The following is a description of a gene set: species: Mus musculus Any process that modulates the frequency, rate or extent of multicellular organismal development. Mouse Gene Set: GOBP_REGULATION_OF_MULTICELLULAR_ORGANISMAL_DEVELOPMENT, and this is the list of marker genes: Osr2, Thbs2, Cdh1, Alox8 (arachidonate 8-lipoxygenase), Racgap1, Uchl5, H2-DMa (NCBI Gene Id 14998), Cul4a, Tnfrsf11b, S1pr1, Lrrtm3, Rbm19, Ccr7, Cxcl12, Mycl, Fxr1 (NCBI Gene Id 99741), Fbxo31, Bmp2, Ptger4, Helt, Pak1, Col4a2, Fam20c, Krt17 (keratin 17), Trpm4, Fos, Spart, Adgrb2, Lrp8, Sorl1 (NCBI Gene Id 72910), Prl8a8, Pla2g3, Ryk, Trp53, Mir124a-2, Six2, Rag2, Zmpste24, Tox, Efnb3, Mysm1, Asic2, Jag1, Dyrk1a, Cdk1, Foxn1, Tlr9, Gab1, Sox4, Id4, Khdc3 (NCBI Gene Id 66991), Plcg1, Dlg1, Lama3, Egr2, Pax2, Lingo4, Sema4d, Fadd, Tnfrsf12a (tumor necrosis factor receptor superfamily, member 12a), Zbtb46, Inpp4b, Pik3r6, Il18, Hoxa11, Smarcc1, Pglyrp4 (peptidoglycan recognition protein 4), Apela, Tmem100, Zfpm1, Vax1, Nlgn2, Il17a, Klf4, Spint1, Tnfrsf1b, D130043K22Rik, Nfkbid, Ppargc1b, Ptk2, Trpc5, Slitrk1, Slc25a4, Bmyc, Wt1, Aplnr, Zeb2, Thrb, Sh3glb1, Kcnk18, Tradd, Mfn2, Clstn1, Rhoh, Ino80d, Lhx2, Smad3, Fgfr1, Ccl21b, Plcb1, Bcor, Mafg, Prl2b1, Akt1, Islr2, Lrrn1 (NCBI Gene Id 72710), Zpr1, Slitrk5, Sgms2, Gpr55, Zzz3, Ythdf2, Rassf10, Itgb2, Lrg1, Smarce1, Ptch1, Rps6ka6, Dcstamp, Cdh4, Hdac2, Hltf, Star, Ski, Dlg5, Csf3r, Mir1a-2, Foxg1, Actr3, Mir675, Erbb2, Prl8a1, Eppk1, Mitf, Foxc1 (NCBI Gene Id 17300), Lep, Tyrobp, Smap1, Rela, Fst, Anxa3, Ano6, Cysltr1, Vgll4, Cst7, Xrcc2, Mbp, Nme1, Numb, Wnt6, Phlda2, Srf, Hax1, Dkk4, Dixdc1, Tcim, Pira12, Tbx3, Prl6a1, Ap3b1, Il5, Hrg, Macroh2a1, F2, Ttc3 (NCBI Gene Id 70444), Metrn, Clasp2, Hhex, Cebpa, Kras, Parp2, Caprin1, Clstn2, Dpysl5, Met, Srrt, Hopx, Tjp1, Actr5, Zfp488, Ccm2, Apcs, Hpse, Sfrp4, Vegfc, Ostn, Fbxw7, Jmjd8, Tal1, Ank, Ppp1r16b, Rassf2, Scin, Trem2, Nap1l1 (nucleosome assembly protein 1-like 1), Mtor, Ephb3, Dnajb11, Atraid, Ctsh, Ctnnbip1, Ptpn2, Tescl, Slit2, Clec4g, S100b, Cd27, Il34, Foxa2, Tdg, Tle6, Twist2, Stat5a (NCBI Gene Id 20850), Fas, Cdkl3, Rgs2, Ceacam1, Braf, Septin7, C3ar1, Kat14, Adcyap1, Tcta, Vhl, Wnt2 (NCBI Gene Id 93808), Bhlhe40, Cx3cl1, Ccl5, Fn1, Prkca, Sos1, Lnpk, Pias3, Chadl, C1qc, Bglap3, Dcx, Il15ra, Plxnb2, Gfi1b, Epha7, Foxj2, Rnd2, Bmp10, Gas6, Pou4f1, Jam2, Cd74, Sp100, Adam8, Klf10, Ocstamp, Grn, Grm5, Maff, Prl8a6, Cxcr3, Fbxo7, Frzb, Gsx2, Shtn1, Trib1, Spry1, Mbd1, Pi16, Tmem176b, Nme2, Trps1, Jun, Cdc73, Tada3, Kitl, Zdhhc21, Shb, Zfp335, Il4i1, Tomm70a, Tmem64, Cartpt, Fgfr3, Hgf, Ptn, C3, Duxbl1, Apoe, Il17f, Pkdcc, Hmga2, Akap5 (NCBI Gene Id 70774), Ctr9, Fbxo5, Csf1, Pin1, Ufl1, Sult2b1, Appl2, Prl7d1, Gadd45a, Mef2c (myocyte enhancer factor 2C), Crabp2 (NCBI Gene Id 99759), Sirt6, Chodl, Il36b, Clec2g, Mustn1, Hook3 (NCBI Gene Id 76095), Esrra, Adam12, Hes6, Pcm1, Plk2 (NCBI Gene Id 20620), Mir125a, Nkap, Dspp, Ezh2 (NCBI Gene Id 14056), Ecscr, Dct, Ntf3, Draxin, Leo1, Itga5 (NCBI Gene Id 16402), Mydgf, Prune1, Iqsec1, Rxrb, Ccn4, Il12b, Ggcx, Igf2, Gm28729, Runx2, Vdr, Tnfsf18, Prl8a2, Gfap, Il17d, Cd109, Erap1, S1pr3, Flrt2, Fam210b, Foxo3, Inhba, Angpt2, Bdnf, Prl4a1, Fshr, Ecm1, Egr3, Lig4, F11r, Sars1, Bcl6, Mkx, Ctdp1, Gbx2, Spen, Cd1d1 (NCBI Gene Id 99710), Lrrc17, Foxa3, Ache, Rxrg, Prok1, Prl5a1, Actr2, Sema4f, Dll4, Poglut1, Vsx2, Hipk2, Sema3e, Mtdh, Ihh, Optc, Ngp, Mapk8, Matn1, Prkch, Il3, Fasl, Bmp7, Lrrtm2, Ddr2, Itgax, Bmpr2, Cers2, Hoxd11, Prkd2, Nrxn1, Nsun5, Prkg2, Fbn1, Fzd4, Syk, Il2, Mboat2, Cyp27b1, Il7r, Smarcd2, Tpbg, Ovol2, Prdm16, Wdpcp, Hspa1b (heat shock protein 1B), Col14a1, Nodal, Rhoa, Rbp1, Cbln2, Smarca4, Otp, Tbx2, Actn3, Il7, Mmp9, Daam2, Zc3h8, Hspb1 (NCBI Gene Id 15507), Tjp2, Fgf1, Sox11, Trip10, Hamp2, Pira1, Fdps, Actl6a, Slitrk2, Lgals9, Rbm10, Mir329, Ppp3ca, G6pdx, Ankrd27, Reln, Fmr1, Yy1, Agrn, Rbm15, Cnmd, Tfpt, Lrrn3, Pilrb1, Rpl4, Marcks, Ell3, Pxn, Mtmr2, Ephb1, Aspm, Epha1, Atf5, Drd3, Nrg1 (neuregulin 1), Prom1, Mir301, S2bpcox16, Pard3, Cyp26b1 (cytochrome P450, family 26, subfamily b, polypeptide 1), Cdkn2a, Map1b, Atp2b1, Cd160, Iapp, Wnt1, Rhob, Hey1, Prmt1, Adgrv1, Rnf10, Angptl3, Clcf1, Anxa1, Notum, Pdcd6, Ptk2b, Trak1, Chd7, Hoxa9, Prl7a2, Gimap3, Tbxa2r, Cav3, Cma1 (NCBI Gene Id 17228), Il1rapl1, Esrp1, Rgs4, Cited2, Wdr62, Xrcc6, Emilin2, Cdkn2b, Sgf29, Smo, Nfkbia, Crtam, Extl3, Jcad, Tbx1, Tespa1, Cit, Adgra2 (NCBI Gene Id 78560), Arhgap4, Fgfr2, Atf4, Gdf2, Igf1, Gjc2, Mup20, Mir23a, Ruvbl1, Tlr3, Drosha (NCBI Gene Id 68645), Ctsc, Hey2, Gpr171, Nell1, Mir27b (microRNA 27b), Pdcd10, Angpt4, Msx1, Abcb10, Heyl, Grhl1, Cdk5, Atp11c, F3, Wnt9b, Acvr2a, Camk2b, Sgpp1, Adgrl4, Rnh1, Sirt2, Mapk7, Lag3, Trak2, Hspb6, Hc, Ldlr, Clec12a, Plxnb1, Tek, Mir219a-2 (NCBI Gene Id 723904), Foxp4 (forkhead box P4), Maf, Ap3d1, Gli1, Adamts7, Rheb, Prkd1, Tnfrsf1a, Gli2, Pax6, Ctdsp1, Ndel1, Ccl2 (NCBI Gene Id 20296), Irf1, Stard13, Ahi1, Tppp, Robo1, Bin1, Pgf, Ascl1, Il23a, Gdf3, Cyp1b1, Six4, Hoxb8, Nkx2-2, Otx2, Prl3d1, Clasp1 (NCBI Gene Id 76707), Nipbl, Ccr1, Fgf9, Idh2, Mir124a-3, Xdh, Ccbe1, Pik3r1, Eif4g2, Vash2, Pkp3, Zfp354c, Gata4, Epn2, Ep300, Map2k1, Nrarp, Dab2ip, Dsg2, Vash1, Lama5, Pnp, Errfi1, Il1a, Atoh1, Pax8, Ago1, Cldn5, Vim, Psen1, Enpp2, Evi2, Zap70, Myoz1, Lta, Six1, Axin2, Tbx5, Myrf, Il1b, Mme, Itgb8, Clec2i, Rc3h1, Mir208a, Cd46, Mt3, Wnk1, Tgif2, Prl2c2, Prl2c3 (prolactin family 2, subfamily c, member 3), Prl7c1, Kat6b, B2m, St8sia2, Tspo, Hmgb1, Slc20a2, Etv2, Limk1, Hhip, Ccl20, Ing5, Hesx1, Nfatc4, Mepe, Pten, Brd7, Brpf3, Pithd1 (NCBI Gene Id 99969), Gli3, Lpin1, Gimap5, Ntrk3, Chi3l1, Vsir, Lama1, Ptprs, Amot, Itgb1, Sox5, Ror2 (NCBI Gene Id 26564), Cd44, Btg1, Dtx1, Twf2, Glg1, E2f2, Lif, Zbed3, Pik3cd, Pias2, Gsdma3, Sart1, Prkcb, Nr2c2, Adgrl3, Ctla4, Prxl2a, Glul, Atg7, Tmem178, Ajap1, Pgk1, Cdh2, Csf3, Wdr5, Cd36, Rras, Insr, Tbc1d24, Dr1, Serpinf1, Acacb, Ctnnb1, Myc, Socs5, Mturn, Slc9b2, Hes2, Fbln5, Hes5, Epha2, Il1rl2, Oprm1, G6pd2 (NCBI Gene Id 14382), Mbip, Apc, Por, Thy1, Ntn1, Hgs, Nlrp3, Map6, Psg22, Nfam1, Tymp, Eif2b2, Hoxb3, Fezf2, Ccr6, Loxl2, Xrcc5, Axl, Fes, Sphk1, Il2rg, Pik3cb, Adgrb1, Lox, Rtn4, Gdf6, Sash3, Nr1d1, Casp8, Slamf8, Cux2, Faim, Spred1, Tgfbr2, Ncmap (NCBI Gene Id 352981), Rnf112, Isl1, Hdac1, Retn, Il21, Yeats2, Trp73, Ccl11, Skic8, Macf1, Ddrgk1, Tbx20 (NCBI Gene Id 77243), Stab1, Nfe2l1, Srebf2, Prelid1, Sox2, Cdk18, Erbb4, Pin1rt1, Lrtm2, Tnfrsf21, Oas2 (2'-5' oligoadenylate synthetase 2), Thbs4, Hes3, Clstn3, Tsc22d1, Mcrs1, Il4, Vegfa, Tnfsf9, Epn1, Parp6, Krt36, Rhoj, C5ar1, Rgcc, Zbtb7b, Ninj1, Adrm1, Stim1, Mapt, Rock2, Eif6, Smarcd3, Lef1, Gja1, Mesp1 (NCBI Gene Id 17292), Kcnk2, Cul7, Tgfb2, Or10j5, Bmpr1a, Bglap2, Grem1, Ppp1cc, Sash1, Acin1, P2rx7, Sox10, Gorasp1, Ndfip1, Kat7, Comp, Myh6, Smarcd1, Sema3a, Nr5a1, Meaf6, Utp25, Srpx2, Bmp2k, Apold1, Hdac6, Nfe2, Sema7a, Efna5, Il4ra, H2-Oa, Prl2a1 (NCBI Gene Id 56635), Ifng, Atf2, Nfe2l2, Dcn, Etv4, Rab14, Rb1 (NCBI Gene Id 19645), Egf, Tspan18, Rarb, L3mbtl1, Ddah1, Cd276, Pafah1b1, Myod1, Plxnd1, Plxnc1, Slc30a1, Xbp1, Tnfrsf11a, H2-Ea, Ptpra, Sh3rf1, Ikzf3, Ncam1, Zmiz1, Mir24-2, Prl3c1, Ephb2, Tnfsf11, E2f1, Adamts1, Snap91, Lck, Asxl2, Rarg, Acvr2b, Neurl1a, Flrt3, Cux1, Prl3b1, Efna3, Il10, Siglec15, Wasf3, Mmp14, Crb2, Ino80b, Plxna3, Ascl2, Lilrb4a, Rest, Keap1, Mir133a-1 (microRNA 133a-1), Plxnb3, Mfn1, Gtf2i, Tnfaip6, Pglyrp3, Amigo2, Pbrm1, Kat2a, Sfrp2, Cxcr2, Tgif1, Jup, Sema5a, Evi2b, H2-M3, Actb, Malt1, Sav1, Lgals1, Pkm, Mettl3, Trpv2, Fgf23, Ptch2, Nkx2-5, Wnt4, Rab7b, Prl8a9, Rnf41, Gdf5, Shank3, Btn2a2, Il12a, Commd5, Picalm, Capn3, Rgma, Fgl2, Gsk3a, Fezf1, Mir223, Dynlt1b, Oxt, Zbtb1, Ankrd54, Vnn1, Bcl11a, Sgms1os1, Ccr5, Zfp418, Gbx1, Pak4, Runx1, Cysltr2, Ccn2, Plg, Amigo3, Tnf, Lgals3, P4htm, Paf1, Adam10, Kat6a, Crhr2 (NCBI Gene Id 12922), Oxtr, Trim46, Qki, Isg15, Adipoq (adiponectin, C1Q and collagen domain containing), Fbn2, Tspan12, Pth, Slitrk3, Wnt5a, Rgn, S100a10 (NCBI Gene Id 99776), Mpl, Dlk1, Grid2 (glutamate receptor, ionotropic, delta 2), Adrb2, Mafb, Man2a1, Prkci, Pik3cg (NCBI Gene Id 76039), Lrp1, Kalrn, Id2, Cx3cr1, Adamts12, Hnrnpk, Cbfb, Rorc, Tnr, Hif1a, Lilrb4b, Wnt7b, Emilin1, Cd40, Agt, Ripk2, Wnt3, Wnt9a, Egln1, Loxl3 (lysyl oxidase-like 3), Foxp3, Acvr1b, Twist1, Suv39h1, Inpp5d, Scx, Tfap2a, Phldb1, Ada, Abl1, Zfp35, Fzd3, Hes7, Zfp365, Ccr3, Adgrl2, Cask, Sox13, Syngap1, Pdpk1, Ferd3l, Sema6d, Ikzf1, Ets1, Fanca, Zfp36, Btg2, Reck (NCBI Gene Id 53614), Rasgrp1, Ccnd2, Bad, Shc1, Gnas, Ipo7, Tada2a (transcriptional adaptor 2A), Cyfip1, Creb1, S1pr2, Dll1, Prl3a1, Cd34, Cdk6, Skint1, Ghrl, Txlng, Epha4, Ctf2, Mia3, Ccl3, Tgm2, Mdga1, Ctla2a, Atp2b4, Flt3l, Faxdc2, Ldb1, Aspa (NCBI Gene Id 11484), Gata6, Actr8, Abcc8, Rgs14, Prdx2, Nfkbiz, Adrb1, Il2ra, Gpr137, Ace (NCBI Gene Id 11421), Rcor1, Cdkn1b, Trf, L1cam, Mecp2, Zfp219, Wnt3a, Reg3a, Pck1, Cdh5, Hnf4a, Fxr2, Clptm1, Eef2k, Stat5b, Il27, Cnot4, Numbl, Cebpb, Gpr68 (G protein-coupled receptor 68, NCBI Gene Id 238377), Ccnd1, Stat3, Nos1, Adamts9, Vegfb, Gh, Srgn, Fbxw8, Tmem119, Hmgb2, Shh, Itgb2l, Ino80 (INO80 complex subunit), Rbfox2, Bag6, Smarcb1, Fgf10, Sema3g, Cd24a, Ptgis, Snw1, Krit1, Atxn1, Egfr, Tgfbr3, Fxn, Sox6, Fzd9, Ube2v2, Odaph, Adm, Gper1, Spi1, Skil, Tiam1, Irgm1, Tafa5, Kdf1, Bmal1, Hspa9, Mapk11, Tob2, Arid1a, Bmp6, Rara, Lrrtm4, Itpka, Cdon, Dag1, Foxc2, Lingo1, Syt4, Bmpr1b, Trp63, Kit, Zeb1, Trim32, Hmox1, Trpc6, Efna1, Bex1, Ruvbl2, Lmo2, Casz1, Rnf6, Cd69, Ripk1, Thoc5, Dab1, Mycn, Klhl25, Hes1, Trip12, Il6st, Zfp683, Bhlhb9, Dlg4, Sirt1, Col4a3, Mir219a-1, Amigo1, Ahsg, Foxp1, Eng, Prpf19, Smad1, Car2, Musk, Camp, Tiam2, Slc4a2, Thpo, Tlx2, Cib1, Synj2bp, Nlgn1, Rbp4, Kdr, Ghsr, Cdkn1c, Gal, Cxcl10, Lrp2, Ifrd1, Elapor2, Kat2b, Prox1, Tgfb1, Ntrk1, Wwtr1, Dmrta2, Smoc2, Fgf20, Jade2, Dusp6, Ccr2, Tfe3, Mag, Adgrl1, Sema3f, Cdh3, Ywhah, Anapc2, Cyld, Arhgef2, Mdk, Itgb3, Prl2c5, Ankle1 (ankyrin repeat and LEM domain containing 1), Ctsk, Carmil2, Mir326, Myo5b, Ppard, Hyal1, Tmem131l, Foxe3, Ltf, Rapgef3, Pdcl3, Mmrn2 (NCBI Gene Id 239033), Lhx1, Tnmd, Tg, Ctnna1, Fig4, Hlx, Angptl7, Rufy3, Ddx39b, S100a1, Gpr37l1, Ifnb1, Serpine2, Mir7-1, Gpm6b, Edn1, Sox9 (NCBI Gene Id 70015), Hoxa5, Prkcz, Ambra1 (NCBI Gene Id 99255), Fstl4, Idua, Arrb2, Shox2, Hap1, Mgp, Pparg, Sh2b3, Fstl3 (follistatin-like 3), Enpp1, Cxcr4, Notch1, Per2, Prl, Lrrc4b, Nf2, Kdm1a, Zc3h12a, Fyn, Clec2d, Ino80c, Hk2, Ngf, Clcn2 (chloride channel, voltage-sensitive 2), Klf7, Akap6, Wnt2b, Bmp1 (NCBI Gene Id 12153), Kl, Mapk14, Rflna, Itgam, Syndig1, Spred3, Ptpn11, Fancd2, Afdn, Yap1, Uts2r (urotensin 2 receptor), Dhx36, Rock1, Dbnl, Slc25a12, Tapt1, Cav1, Sparc, Reg3g, Efemp1, Cbln1, Ncoa3 (NCBI Gene Id 99361), Acvr1, Bglap, Fgf2, Arhgap32, Meis2, Gata1, Ccsap, Dlx1, Nras, Sfn, Gata3, Cd28, Agtr1a, Tlr2, Cftr, Sgk1, Flrt1, Wnt10b, Zfpm2, Ltbp3, Slitrk6, Pim1, Add1, Il15, Brd2, Foxj1, Pkp1, Bhlhe41, Meis1, Apoh, Ikbkb, Rag1, Senp1, Zfp36l2, Lrp4, Obsl1, Lgi4, Il1rap, Cldn18, Msx2, Ehmt1, Wars2, Notch2, Hcls1, Nbr1 (NCBI Gene Id 17966), Mir27a (microRNA 27a), Ist1, Zfp609, Cd59a, Rab21, Slc8a1, Golga4, Atoh8, Adnp, Zfp36l1 (zinc finger protein 36, C3H type-like 1), Smpd3, Lpar3, Macroh2a2, Baiap2, Stk11, Sall1, Ptprc, Nkx3-2, Rptor (NCBI Gene Id 74370, regulatory associated protein of MTOR, complex 1), Dip2b, Robo2 (NCBI Gene Id 72126), Nlgn3, H2-Aa, Lama2, Phf10, Il20, Pml, Tcf7l2, Adm2, Slitrk4, Pinc, Cip2a, Nkx2-2os, Ism1 (NCBI Gene Id 99286), Akap11, Fgf18, Thbs1, Ccr1l1, Rtn4r, Slc12a2, Ilk, Phospho1, Slc39a12, Gjd4, Yjefn3, Klf2, Map2, Srsf6, Ulk1, Tmem176a, Zbtb16, Nr3c1, Traf6, Drd2, Ifitm5, Dscam (DS cell adhesion molecule), Ptpn6, Tenm4, Amtn, Ppp2r3c, Nlrp5, Brd4 (NCBI Gene Id 57261), Vcl, Prlr, Wars1, Sos2, Mir23b, Nkx6-1, Uts2, Fkbpl, Lrrc24, Pitx3, Hmgb3, Nkx6-3, Wnt7a, Tnfsf4, Prkdc, Rc3h2, Map2k2, Flt3, Cfl1, Prl3d2, Vezf1, Rapgef2, Gdi1, Tgfbr1, Actl6b, Akt3 (NCBI Gene Id 98462), Htatip2, Sox12, B4galt5, Noct, Itpkb, Mir150, Cd83, Myb, Golga2, Sox17, Ss18l1, Prdm1, Anxa2, Prmt5, Ago2, Sema6c, Gata2, Naxe, Slc7a5, Kctd11 (potassium channel tetramerisation domain containing 11), Erfe, Olig2, Bmper, Tbx21, Lingo2, Stk25, Med1, Hsf1, App, Smarca2, Caprin2, Clic3, Fgf13, Sec1, Kifap3, Ccn6, Sox15, Dock7, Nrp1, Rfx3, Klf13 (NCBI Gene Id 80528), Ccl19, Prl7b1, Sfrp1, Cybb, Notch4, Nrdc, Pde3b, Pou4f2, Aspn, Gsk3b, Bag1, Dll3, Tert, Mir24-1, Dicer1, Jak3, Adgre5, Gdnf, Nedd9, Tie1, Hsp90aa1, Mir133a-2, Sox8, Mapk1, Nr2e1, Emp2, Zbtb7a, Lrtm1, Adcy10, Tsc2, Ramp2, Snai2, Smad4, Zcchc24, Nin, Mir124a-1, Il33, Ptprz1, Ptpn13, P2rx5, Pcid2 (NCBI Gene Id 234069), Cxadr, Gdf9, Zfp608, Tnn (tenascin N), Sema4a, Rbpj, Dmp1, Spred2 (sprouty-related EVH1 domain containing 2), Lin28a, Aggf1, Hoxa7, Brinp1, Ptprm (protein tyrosine phosphatase receptor type M), Tcf7, Dlx2, Trim11, Brca1, Card11, Zfyve27, Gabpa, Ulk2, Hamp, Prl3d3, Aqp1 (NCBI Gene Id 11826), Brd1, Hspa5, Cd40lg, Nfrkb, Id1, Ager, Acvrl1, Tmem98, Tcf4, Pak3, Stat1, Socs1, Spry2, Ppara, Ccnb1, Fermt1, Pglyrp2, Ccl24, Nefl (neurofilament, light polypeptide), Dusp10 (dual specificity phosphatase 10), Setd1a, Ppp1r15a, Nlrp4f, Synj1, Spaar, Kat5, Foxo4, Smurf1, Cela1, Grip1 (NCBI Gene Id 74053), Map3k13, Plag1, Adgrb3, Rack1, Jak1, Cdkl5, Xrcc4, Etv5 (ets variant 5), Stau2, Emc10, Dkk1, Phldb2, Arid2, Wls, Prl2c1, Lama4, Smad7, Cited1 (NCBI Gene Id 12705), Pf4, Minar1, Vstm5, Nckap1l, Slit1, Cd4, Bmp4, Flt1, Prl7a1, Gpr137b, Nupr1, Fat4, Cemip2, Ubash3b, Abca12, Disc1, Tesc, Proc, Creb3l1, Fshb, Nptn, Prtg, Ptprf, Dbn1, Runx3, Nf1, Nog, Sulf1, Kif14, Serpine1, Cd101, Csf1r, Osr1, Gpr4, Dmbt1 (NCBI Gene Id 270001), Pglyrp1, Megf8, Ccn1, Ntrk2, Ypel4, Enam, Smarcc2 (SWI/SNF related, matrix associated, actin dependent regulator of chromatin, subfamily c, member 2), Ccl9, Tent5a (NCBI Gene Id 320335), Rxra (retinoid X receptor alpha), Alox5, Dnm1l, Ptprd, Lyn (NCBI Gene Id 99963), Pthlh, Opa1, Il6, Eeig1, Nkx6-2, Tnik, Xlr3b, Slc46a2, Prkx, Kdm4a, Numa1, Ahr, Fut1 (fucosyltransferase 1), Eif2ak3, Nr5a2, Rflnb, Lrrtm1, Sema6a, Jarid2, Iqsec2, Nos3, Ngfr, Krt84, Pax4, Sp1